Given this list of marker genes ACTR8, H2AC21, H2AC13 (H2A clustered histone 13), PSMA5, RPS27A, H2AC7, H2AC6, UCHL5, H2AC1, TFPT (NCBI Gene Id 29844), TGFBR1, RUVBL1, UCHL1, INO80E, H2AC15, H2AC12, TGFBR2, ACTB, MCRS1, INO80C, H2AC16, PSMB3, PSMD13, UBA52, PSMD11 (proteasome 26S subunit, non-ATPase 11), PSMD1, PSMD12, USP15, H2AC17, PSMB1, BAP1, NEDD8, PSMD7, MBD5, TGFB1, H2AC4, PSMD6, YY1, PSMB2, PSMA4, PSMC1, KDM1B, H2AC19, INO80D, HCFC1, PSMC2, PSMB7 (proteasome 20S subunit beta 7), H2AC14, PSMD3, ASXL2, SEM1, PSMA6, NFRKB, PSMD8, BARD1 (BRCA1 associated RING domain 1), H2AC18, PSMA7, PSMC5, UBC, PSMD14, UBB, OGT, PSMA3, H2AC8, UCHL3, PSMC3, ADRM1, H2AC20 (NCBI Gene Id 8338), H2AC25, PSMC6, FOXK2, PSMB4, SMAD7, PSMB6, PSMB5, ASXL1, MBD6, PSMC4, PSMD2, H2AC11, PSMA1, FOXK1, ACTR5, PSMA2, INO80, SENP8, ACTL6A, INO80B, here is a description of the gene set: UCH proteinases Human Gene Set: REACTOME_UCH_PROTEINASES species: Homo sapiens